The following is a description of a gene set: studied in species Mus musculus A process in which a monoatomic ion is transported across a membrane. Monatomic ions (also called simple ions) are ions consisting of exactly one atom. Mouse Gene Set: GOBP_MONOATOMIC_ION_TRANSMEMBRANE_TRANSPORT, and this is the list of marker genes: Calhm5 (calcium homeostasis modulator family member 5), Zfas1, Scnn1b, Cnnm2, Sec61a1, Jsrp1, Slc6a9, Tmem120a, Pkd1l1, Slc22a1, Gria2, Osr1, Atp6v1d, Slc6a14, Atp1b1, Slc6a4 (NCBI Gene Id 216958), Gria3, Alg10b, Kcns2, Kcnd3, mt-Co2, Akap9, Atp5mc3 (NCBI Gene Id 277484), Kcna7, Tmco3, Tmem168, Cacng8, Gpr35, Kcnip3, Kcng1, Kcnt1, Slc25a23, Atp4b, Ms4a2, Slc30a4, Fxyd6, Best3, Rgs7, Atp5f1a, Catsper3, Bsnd, Mmgt2, Gabrb2, Slc23a1, Pacc1 (proton activated chloride channel 1), Gabra5, Gria1, Slc26a1, Trpm6, Cxcl10, Glrb, Ttyh2, Gp9, Cemip, Itgb3, Plch2, Flna, Rnasek, Scn8a, Kcne1, Chrm5, Ywhah, Trpc6, Fxn, Pik3cg, Htr3a, Slc41a3, Slc12a2, Iscu, Bhlha15, Hvcn1, Phb2, Kcnj2, Trpm8, Tgfb2, Ednra, Cnksr3, mt-Atp6, Steap2, Nr3c2, Kcng4, Grm6, Tmem175, Vamp2, Homer1, Slc18a3, P2rx6, Ppp3r2, Mrln, Ibtk, Slc18a1, Trpm4, Slc12a4 (NCBI Gene Id 20498), Ucp1, Tmem165, Ank3, Nherf1, Clcn6, Kcnj13, Tmem94, Slc9a1, Fxyd2, Slc30a3, Lrrc8a, Epo, Scn4b, Cacng2, Fmr1, Atp6v1e1, Rem1, Asic3, Stom, Tcirg1, Nlgn3, Cpox, Kcnd1, Calm2, Cblif, Cacnb3, Kcne3, Gabrb1, P2rx1, Cav3, Chrnb4, Cyc1, Kcnk6, Kcns3, Pirt, Ap3d1, Slc9b1, Cxcr3, Cacna1g, Gnb2, Kcnc3, Scn2a, Coro1a, Slc12a5, Kcnip4, Ywhae, Cacna1c, Cacnb1, Ctns, Ccl19, Mettl21c, Grin2b, Ednrb, Ndufs7, Chrna2, Slc4a8, Atp1a3, Slc39a10, Gp1ba, Ghitm, Dmac2l, Stim1, Mfsd8, Slc6a3, Gabrr1, Kcnc1, Cbarp, Adcyap1r1, Slc1a1, Cd19, Glp1r, Nipal1, mt-Nd1, Slc25a22, Hamp, Slc39a14, Nnt, Atp1a1, Kcnh8, Ptger3, Gp1bb, Scn10a (sodium channel, voltage-gated, type X, alpha), Slc6a21, Pln, Ptk2b, Scnn1a, Htr2a, Hrc, Slc18b1, Lrrc26, Trpc4, Lyn, Atp6v1a, Slc30a5, Slc6a2, Atp5pb, Atp6v1b2, Ncs1, Jph3, Fkbp1a, Slc9c1, Clca3a1, Slc8a2, Slc12a7, Fgf2, Akt1, Nherf2, Grm7, Kcnj4, Kcna2, Rnf207, Rgs9, Nipa2, Slc6a18 (NCBI Gene Id 22598), Kcnmb1, Slc45a3, Xcl1 (NCBI Gene Id 98422), Ndufv1, Nos1, Sumo1, Slc9a4, Slc6a17, Gp5, Kcne5, mt-Nd4l, Tmco1, Sfxn4, Atp5me, Slc4a3 (solute carrier family 4 (anion exchanger), member 3), Slc4a1, Slc6a8, Kcnq1 (NCBI Gene Id 547397), mt-Cytb, Cacna1e, Chd7, Plcg2, Scn2b, Calhm2, Hcn1, Ahnak, Piezo1, Commd1, Slc20a2, Ccl19-ps6, Ndufs2, Cox4i2, Slco1a8, Slc25a13, Cacna1h, Atp6v0e2, Trpc7, Fgf14, Kcnab2, Diaph1, Slc26a6, Slc25a27, Prss8, Slc25a5, Atp7a, Htr2c, Hpca, Dmd (NCBI Gene Id 93863), Atpsckmt, Kcnn2, Ccl19-ps3 (NCBI Gene Id 65959), Vdac1, Ank2, Calhm6, Hpn, Fxyd3, Galr2, mt-Co1, Kcnf1, Atp6ap1, Slc25a37, Piezo2, Abcc2, Slc13a3, Gpd1l, P2rx7, Tpcn2, Chrna4, Tesc, Cacna2d2, Slc6a20a, Kcnk12, Drd4 (dopamine receptor D4), Ndufv2 (NADH:ubiquinone oxidoreductase core subunit V2), Pdpk1, Grxcr1, Sfxn2, Kcnk10, Agtr1a, Ywhaq, Calhm3, Abcb6, Slc9a8, Tmem74, Slc47a2, Ndufs4, Slc31a2, Kcnn1, Xcr1, Slc1a3, Cnga2, Stim2, Chrna10, Ddit3 (NCBI Gene Id 13198), Slc30a9, Gabra2, Abcb8, Bpifa1, Gas6, Atp6v0a4, Mtor, Trpm7, Gabrr2, Scnn1g, Tmem109, Micu1, Trpc2, Ccl19-ps1, Atp6v1e2, Kcnq3, Abcc5, Slc17a7, Slc6a6, Tmem38b, Lck, Hif1a, Pml, Kcnb1, Grin2a, Cnnm4, Coa8, Htr3b, Plcb4, Slc39a7, Ccl21d, Cav1, Tgfb1, Casq2, Scara5 (NCBI Gene Id 74378), Scn3a, Lrrc8e, Ndufa4, Scn7a, Opa1, Ppif (peptidylprolyl isomerase F (cyclophilin F)), Pawr, Slc38a2, Kcnd2, Hcn3, Cybb, Aplnr, P2rx4, Lrrc8b (leucine rich repeat containing 8 family, member B), Akap5, Ccl19-ps4, Dysf, Dhrs7c, Kcnk18, Npsr1, F2r, Atp5f1e, Kcnk1 (potassium channel, subfamily K, member 1), Kcnk5 (NCBI Gene Id 16529), Atg5, Slc45a1, Snap25, Snta1, Atp5mg, Fasl, Anxa6, Ctss, Kcnj12, Neto1, Gabrg1, Atp5mc1, Ntsr1, Clic4, Ero1a, Ndufb7, Cacna1f, Dbi, Pkd1l3, Ano3, Gabrg3, Slc20a1, Gnb5, Slc25a28, Cnga4 (cyclic nucleotide gated channel alpha 4), Slc46a1, Kcnj16, Oga, Atp2b4, Panx1, Letm2, Stac, Hamp2, Clcn4, Chrnb1, Nedd4, Trpv3, Kcnj5, Slc12a1, Kcna6, Ifng (interferon gamma), Slc24a2, Surf1, mt-Nd2, Slc39a13, Slc41a1, Panx2, Orai1, Cftr, Asic1, Smim6 (NCBI Gene Id 68528), Slc9a5, Kcng3, Nalf2 (NALCN channel auxiliary factor 2), Slc5a5, Slc39a11, Ppp3r1, Slc39a3, Slc5a1, Gjd3, Amigo1, Chrna1, Trdn, Kcnk2, Tmem37 (NCBI Gene Id 98701), Ccl21f, Slc17a6, Ndufs3, Slc26a3, Slc48a1, Scn1a, Dlg1, Cacna1s, Bpifa5, Atp6ap2, Kcnk9, Chrnd, Romo1, Atp6v1c1, Catsper4 (cation channel, sperm associated 4), F2rl3, Wnk3, Cacng6, Slc4a11, Cacna2d1, Clcn5, Clic6 (NCBI Gene Id 209195), Atp13a3, Slc34a3, Slc6a19 (NCBI Gene Id 74338), Slc38a1, Bin1, Adra1a, Fhl1, Kcnma1, Gabra1, Gabre, Abcb7, Agrn, Tmc1, Cxcl11, Nipa1, Atp6v1h, Slc39a6, Itgb1, Plcb1, Slc6a16, Dpp10, Mcur1, Mrs2, Slc26a7, Cldn4, Atp2a2, Jph2 (junctophilin 2), Slc25a18, Ptpn3, Htt, Asic4, Kcnab3, Clic5, Best2, Ccl19-ps5, Bdkrb1, Stac3, Pkd2l1, Asic2, Cacng3, Fgf12, Grp, Catsper1 (cation channel, sperm associated 1), Grik2, Kcnh3, Kcnq4, Capn3, Kcnk15, Ms4a1, Prkd1, Slc5a6, Hspa9, Kcna5, Slc24a5, Atp2a3, mt-Nd5, Atp6v1b1, Slc30a7, Slc24a4, Ccl3, Slc12a3, Bax, Ikbkb, Tmem63b, Nipal2, Slc11a1 (NCBI Gene Id 18173), Plcb3, Clca1, Ahr, Mcoln1, Micu3, Micu2, Slc12a8, Hspa2, Stk39, Atp6v0c, Itpr1, Slc13a1, Ubqln1, Zdhhc13 (zinc finger, DHHC domain containing 13), Plch1, Cacna2d3, Fxyd1, Calhm1, Selenon, Ptpn6, Slc9a3, Ano5, Ttyh1, Kcnj11, Clcnkb, Grik3, Slc9b2, Tfrc, Bak1, Slc39a1, Scn5a, Slc5a4b, Ano1, Pcsk9, Atp6v1g1, Slc25a14, Clcn3, Trpm5, Slc34a2, Atp13a2, Drd1, Slc39a4, Kcnj15, G6pdx (glucose-6-phosphate dehydrogenase X-linked), Vdac2, Kcnip2, Slc39a12, Slc25a25, Atp2b2, Plce1, Slc12a6, Ehd3, Steap1, Slc39a9, Heph, 1810037I17Rik (RIKEN cDNA 1810037I17 gene), Sphk2, C2cd6, Kcna10, Atp5f1b, Slc31a1, Tusc3, Kcnh6, Oxsr1, Gja1, Pcyox1, Hrh1, Tpcn1, Orai3, Fcrl5, Atp6v1c2, Spg7, Kcne2, Ucp3, Glra1, Trpm1, Gpm6a, Fbxo11, Glra3 (NCBI Gene Id 14656), Kcnj8, Chrna3, Kcnj3, Kcnrg, Slc36a1, Cnga1, Slc39a2, Cacng4, Cherp (NCBI Gene Id 70519), Hap1, Cldn17, Plcb2, Clca4a, Atp2b3, Steap4, Aqp6, P2ry6, Tmem38a, Abl1, Gabrd, Panx3, Chrnb3, Rapgef3, Fxyd5, Atp5po, Kcnk16, Ccl21a, Sestd1, Mmp9, Ppp3cb, Chp1, Ccn2, Gabrb3, Grik5, Tcaf1, Atp5pd, Trpv6, Catsper2, Kcnk13, mt-Nd4, Cacna2d4, Slc29a4, Chrng, P2rx5, Slc30a10, Itpr3, Kcne4, Atp6v0a2, Atp13a5, Atp1a4, Slc26a5, Psen2, Kcnh5, Edn1, Kcnj1 (potassium inwardly-rectifying channel, subfamily J, member 1), Slc32a1, Grik4, Gjc2, Trpv2, Atp6v1f, G6pd2, Afg3l2, Gsto1, Kcnh2, Gjc1, Slc11a2, Atp2c1, Cacnb2, Fgf13, Ffar1, Slc30a2, Cox7a1, Mcu, Kcnb2, Kcnh1, Slc4a10, Sfxn5, Atp1b2, P2rx2, Slc6a1, Kcnn3, Slc26a4, Cx3cl1, Slc6a20b, Grid2, Slc16a1, Snca, Gabra6, Slc1a2, Atp5mc2, Slc6a5, Edn3 (NCBI Gene Id 13616), Slc39a5, Arf1, Lasp1, Plcg1 (phospholipase C, gamma 1), Pde4d, F2, Kel, Dpp6, S100a6, mt-Atp8, Atp5f1c, Cd63 (CD63 antigen), Kcnj14, Atp2a1, Kcnv2 (NCBI Gene Id 240595), Kcnj10, Ano7, Slc40a1, Cyba, Atp6v1g3 (ATPase, H+ transporting, lysosomal V1 subunit G3), Cxcl9, Cox17, Lrrc38, Bcl2, Steap3, Vdac3, Orai2, Ano2, Gal, Slc13a2, Stimate, Gria4, Tmbim6, Ubr3 (NCBI Gene Id 99175), Kcna4, Pkd1, Kcnh4, Slc38a5, Ngf, Maip1, Mlc1, Gabrq, Kcnab1, Lrrc8c, Trpm2, Reln, Slc13a5 (NCBI Gene Id 405903), Kcnt2, Slmap, Tmc4, Calm1, Apol11a, Trpc5, Prnp (prion protein), Tmem150c, Slc6a15, Wnk2, Plcl2, Ucp2, Lhcgr, Ubash3b, Lrrc55, Tcn2, Akap7, Slc5a4a, Gimap5, Asph, Gimap3, Aqp1, Ndufs1, Atp6v0a1, Gabra4, Slc45a2, Cacnb4, Slc6a7, Gpr89, Slc4a7, Atp6v0b, Slc12a9 (solute carrier family 12 (potassium/chloride transporters), member 9), Chrna6 (cholinergic receptor, nicotinic, alpha polypeptide 6), Trpv4, Ryr3, Clcn1, Ppp3cc, Slc6a11, Ryr1, Ano8, Slc25a12, Kcnc4, Gabrp, Slc18a2, Atp12a, Slc39a8, Cd4, Kcnu1, Adrb2 (adrenergic receptor, beta 2), Kcna3, Ano10, Sln, Slc8b1, Sting1, Nedd4l, Chrne, Slc46a3, Slc30a8, Ndufs8, Hcn2, Psen1, Atp5f1d, Abcb1b, Grik1, Slc5a3, Plcl1, Mcub, Tlr9, Kcna1, Ano6, Slc25a4 (NCBI Gene Id 11739), Otop1, P2rx3, Slc30a6, Ndufa2, Uqcrh, Slc8a3, Gstm7, Fxyd7, Lcn2, Slc26a10, Cacna1d, Mmgt1, Rgs4, Tmc2, Tmem63c, Itpr2, Scn4a, Smdt1, Myo5a, Mcoln2 (NCBI Gene Id 99673), Nalcn, Gopc, Trpv1 (transient receptor potential cation channel, subfamily V, member 1), Ptpn22, Kcnv1, Kcnip1, Slc15a2, Fkbp1b, Slc9a6, Prkce, Bmp4, Nol3, Kcnc2, Wwp2, Trpc1 (NCBI Gene Id 22063), Uqcrfs1, Kcnk7, Oprk1, Scn3b, Abcb1a, Slc47a1, Pkd2, Asic5, Rangrf, Slc26a2, Slc6a13, Nipsnap2, Itgav, Scn1b, Slc9a9, Grin2c, Strit1, Large1, mt-Co3, Slc26a8, Grin3a, Atp5pf, Wnk4, Lime1, Slc30a1, Ripk1, Cacna1i, Slc4a2, Il4, mt-Nd3 (mitochondrially encoded NADH dehydrogenase 3), Slc19a1, Atp1b3, Slc9a7, Cnga3, Gabrr3, Slc24a1, Trpa1, Atox1, Casr, Akap6, Gper1, Kcnmb4, Kcnh7, Kcnn4, Nipal3, Atp5mf, Pik3c2a, Ndufa10, Wnk1, Chrna7, Pkd2l2, Atp6v0e, Sco1, Clic1, Gabrg2, Cngb1, Slc4a4, Kcng2, Calm3, Wnt3a, Calhm4, Slc25a3, Slc6a12, Casq1, Nipal4, Chrna5, Kcnmb2, Nmur2, Otop2, Ppp3ca, Slc4a9, Nalf1, Mcoln3, Trpv5, Thy1, Atp7b, Slc15a1, Oca2 (NCBI Gene Id 18431), Slc5a2, Trpm3, Cacng1, Best1, Slc24a3, Ano4, Atp6v0d2, Clcnka, Atp4a, Slc1a4, Cacng7, Atp6v0d1, Abcc9, Ccl21e, Cacna1b, Crbn, Atp2c2, Sfxn1, Letm1, Cngb3, Hcn4, Plp1, Drd2, Stac2, Slc26a9 (solute carrier family 26, member 9), Slc4a5, Il13, Slc17a8, Grid1, Slc15a4, Taco1, Lrrc52 (leucine rich repeat containing 52), P2ry12, Actn2, Slc36a2, Slc8a1, Kcnj6, Htr2b, Kcns1, Clic3, Abcc3, Ano9, Slc41a2, Slc45a4, mt-Nd6, Nppa (NCBI Gene Id 230899), Ccr5, Ccl21b, Chrna9, Atp13a4, Scn9a, Fxyd4, Atp2b1, Kcnk3, Otop3 (NCBI Gene Id 69602), Tescl, Gpr39, Clec4b1, Tmem63a, Ccdc51, Chrnb2, Gabra3, Vmp1, Clca2 (chloride channel accessory 2), Slc28a3, Camk2d, Glra4 (glycine receptor, alpha 4 subunit), Atp6v1g2, Slc36a3, Atp1a2, Kcnk4 (potassium channel, subfamily K, member 4), Clcc1, Slc26a11, Slc34a1, Ryr2, Slc9a2, Kcnq2, Glra2, Grin1, Sri, Slc38a4, Slc1a7, Gm13629, Scn11a, Fyn, Tmem163, Lrrc8d, Cracr2a, Adrb1, Trpc3, Ttyh3, Cacna1a, Sfxn3, Grin2d, Grin3b, Kcnq5, Clcn2, Tspan13 (NCBI Gene Id 66109), Slc35g1, Clcn7, Kcnj9, Ptprc